Given this list of marker genes GDI1, BARD1, FAM76B, PIAS4, YWHAZ, SREBF1, FBXO4, MAP1A, RIPOR2, NSFL1C, DRD2, ROCK2, HMGCR, LATS2, ABHD17B, IL12A, SNX12, MIR93, DMTN, TMEM59, SNX3, ACVR1C, SFN, MAPT, ADTRP, INSIG1, YWHAB, PARK7, RAB11FIP1, MIDN, MRAP2, LZTFL1, COMMD1, OTUD7B, NR1H3, INHBB, SP100, SPI1, WNK4, SYTL4, SUFU, GRIPAP1, IDH2, HDAC3, NDFIP1, PIM3, MARK3, INPP5K, MAGED1, F2RL1, PDE8B, RHBDF2, GPM6B, TRIM40, TAX1BP3, KCNB1, RAB11FIP5, BAG3 (BAG cochaperone 3), SIN3A, WNK1, ABHD17C, ACTN2, SERGEF, SUMO1, LRRK2, RANGAP1, AP2M1, INS, UBAC2, RHOQ, DRD3, GDI2, ILRUN, MIR19B1, MIR146A (NCBI Gene Id 406938), PRKN, CYP51A1, DCLK2, POLR1A, FERMT1, MDFIC, BTF3, WWP2, GHSR, YOD1, MTOR, ASTN2, LATS1 (large tumor suppressor kinase 1), ABCC8, SIRT4, LRRC15, RSAD2, ERLEC1, KLF7, MIR30C1, TRIM29, ADIPOQ, SYT4, LZTS2 (NCBI Gene Id 84445), ABI3, ERP29, APOE, IL1B, LYPD1, CCN3, MACROH2A1, CABP1 (calcium binding protein 1), FFAR2, CLTC, USP17L2, NEO1, DPH3, IL12B, NF1, WNK3, AKT1, BCL2L1, OPRM1, NDUFAF2, JAGN1, SVIP, GHRL, FRMD4A, CD200, ADRA2C, MIR148A, RHBDF1, ARF6, MIR29B1, C11orf65, GOPC, PKDCC, ENY2, PSMD9 (proteasome 26S subunit, non-ATPase 9), CD36, DERL3, LEPROT, F2R, DERL2, TERF1, TMEM98, ANGPT1, PPFIA1, EI24, GBP1, HADH, ADRA2A, CHGA (NCBI Gene Id 1113), RNF4, CLDN18, CDK9, TMBIM1, CDK5, INPP5E, TP53INP2, GSK3B, PTPN11, MTNR1B (NCBI Gene Id 4544), REST, KCNE1, FKBP1B (FKBP prolyl isomerase 1B), PKIA, LNCPRESS1, CHP1, GNAO1, SIRT6, MIR128-1, FZD9, TMED2, PKIG, PPM1F, NDFIP2, DRD4, PPP2R5A, LYPLA1, GNAI1, TGFB1, CTNNA1, PICALM, PID1, GNAZ, FOXO1, UFM1, ANKRD13A, ABHD17A, TXN, NUMB, IRS1, TTBK2, CAV3, RAB23, UBXN2B, PFKL, MIR19A, NEDD4L, MFHAS1, SIAH3, APP, NPFF, CORO2B, VSNL1, CSK, LYPLAL1, RAB11FIP3, UBE2J1, LILRB4, UBE2G2, MRAP, SAPCD2, DNAJA1, BMP8A, NACA (nascent polypeptide associated complex subunit alpha), MIR766, FAM3D, APOD, OS9, MIR199A1, DAB2, UCP2, SNX33, ITGB1BP1, VPS35, LMAN1, KCNJ11, VCP, ANXA13, NFKBIA, BAG4, RSC1A1, here is a description of the gene set: Human Gene Set: GOBP_NEGATIVE_REGULATION_OF_PROTEIN_LOCALIZATION studied in species Homo sapiens Any process that stops, prevents or reduces the frequency, rate or extent of a protein localization.